The following is a description of a gene set: studied in species Homo sapiens Defects in MMADHC cause methylmalonic aciduria and homocystinuria type cblD (MMAHCD; MIM:277410), a disorder of cobalamin metabolism characterized by decreased levels of the coenzymes adenosylcobalamin (AdoCbl) and methylcobalamin (MeCbl). Reactome Pathway: Defective MMADHC causes MMAHCD part of: Defects in cobalamin (B12) metabolism, and this is the list of marker genes: MMADHC, MMACHC